Given this list of marker genes Hk1, Myc, Stat3, Ins2, Tpi1, Prkaca, Slc1a3, Aco1, Shpk, Gapdhs, Prkag1, Sarm1, Ldha, Rpe, Trp53, Gpd1, Fmo2, Hnf1a, Kmo, Pcx (pyruvate carboxylase), Mpi (NCBI Gene Id 66909), Bcl10, Arl2, Gapdhrt2 (NCBI Gene Id 434330), Ifng, Hsd11b1, Pkm, Slc25a13, Aldh1l2, Nupr1, Zbtb20, Prkag3, Slc37a2, Aldoart2, Git1, Mlst8, Aldoart1, Haao, Pdxp, Aldoc, Nadsyn1, Khk, Slc25a11, Nudt13, Nudt12, Nmrk2, Rptor, Pnp2 (purine-nucleoside phosphorylase 2), Art2b, Kat2b, Extl3, Actn3 (actinin alpha 3), Idh2, Jmjd8, Mdh1, Prps1, Eno3, E2f1, Bpgm, Pfkfb1, Ier3, Xiap, Ins1, Ogt, Dlst, Insr, Galk1, Me1, Pfkp, G6pd2, Nudt17, Pgd, Pfkl, Tigar, P2rx7, Ncf1, Myog, Enpp1, Adpgk, H6pd (hexose-6-phosphate dehydrogenase (glucose 1-dehydrogenase)), Me2, Esrrb (NCBI Gene Id 26380), Hk2, Sik2, Prkaa1, Igf1, Hdac4, Kynu, Gale, Eno1b, Slc25a12, Eno4, Cbfa2t3, Plpbp, Aldob, Hk3, Fkrp, Gapdhrt, Il3, Noct, Pgam2, Slc4a1, Taldo1, Ddit4, Pdxk, Eif6, Foxk2, Idh1, Ido1, Ep300, Gpd2, Got1, Vcp, Aspdh, Reg3g, Tkt (NCBI Gene Id 21881), Parp14, Pgam1 (phosphoglycerate mutase 1), Col6a1, Pklr, Trex1, Mlx, Gck, Gapdh, Nnt, Gpd1l, Tkfc, Ppargc1a, Mdh1b, Eno2, Prps2, Slc25a18 (solute carrier family 25 (mitochondrial carrier), member 18), Hkdc1, Uchl1, Mtch2, Pfkfb3, Pfkm, Dcxr, Qprt, Rbks, App, Nmrk1, Nadk2, Trim63, Pgk1, Rac1, Ogdh, Dhtkd1, Naxd, Foxk1, Src, Eno1, Macroh2a1, Mdh2, Gpi1, Pgls, Slc4a4 (NCBI Gene Id 54403), Rpia, Mlxipl, Ppp2ca, Nadk (NAD kinase), Nmnat2, Aox1, Slc25a51, Htr2a, Psen1 (presenilin 1), Nnmt, Galt, Ido2, Pgk2, Pnpo, Sirt6, Mtor, Hif1a (hypoxia inducible factor 1, alpha subunit), Nmnat3, Prkaa2, Afmid, Ncf2, Ldhb, Htt, Lipa, Acacb, Pfkfb2, Bin1, Bcl2l13, Got2, Aldh1l1, Slc25a22, Nampt, Ucp2, Aldoa, G6pdx (NCBI Gene Id 14381), Prxl2c, Slc2a6, Prkag2, Pnp, Ncor1, Naprt, Acmsd, Naxe, Art2a, Fbp1, Nmnat1, Ppara, Arnt, Mfsd8, Alpl, Flcn, Zbtb7a, Cyb5r4, here is a description of the gene set: The chemical reactions and pathways involving a pyridine-containing compound, i.e. any compound that contains pyridine or a formal derivative thereof. species: Mus musculus Mouse Gene Set: GOBP_PYRIDINE_CONTAINING_COMPOUND_METABOLIC_PROCESS